Given this list of marker genes PANX2, GJA10, PANX1, GJD2, GJC1, here is a description of the gene set: Human Gene Set: REACTOME_ELECTRIC_TRANSMISSION_ACROSS_GAP_JUNCTIONS Electric Transmission Across Gap Junctions studied in species Homo sapiens